The following is a description of a gene set: species: Homo sapiens Human Gene Set: GSE27786_LIN_NEG_VS_MONO_MAC_UP from publication Konuma T, Nakamura S, Miyagi S, Negishi M, Chiba T, Oguro H, Yuan J, Mochizuki-Kashio M, Ichikawa H, Miyoshi H, Vidal M, Iwama A (PMID 21540074) Genes up-regulated in comparison of lineage negative versus monocyte macrophages. Each fraction of mouse hematopoietic cells was purified by cell sorting from bone marrow of 8-week-old C57BL/6 mice, and its gene expression was analyzed., and this is the list of marker genes: CFAP418, DHFR, UBR7, RPP14, IFT27, GINS1, DTYMK, THNSL1, TDP1 (tyrosyl-DNA phosphodiesterase 1), NOC3L, PSMD2, SACS, ECD, PUS3, CHD9, METTL15, MFHAS1, STRAP, SEPTIN8, AP1B1, ARID1B, RDX, IPO11, HRAS, WIPI2, ARK2C, BCLAF1, SNHG6, ARFGAP3, MED13, USP15, UTP20, TRRAP, ECI2, MCM3, SH2D4A, TELO2, TBRG4, CSGALNACT1, TRIM27, DNAJA4, CXCL13, ABITRAM, NEK2, TMEM178A, NCBP2, AMACR, LIAS, TEX10, ZNF799, PTRH2, ESAM, ART4, TMEM39B, EARS2, TFPI (NCBI Gene Id 7035), TCF12, RASA4, DNAJC21, DYNC2I1 (NCBI Gene Id 55112), IARS2, RNMT, PIAS2, RPUSD2, ARB2A, FAM241B (family with sequence similarity 241 member B), CYB5R3 (NCBI Gene Id 1727), INSIG1, EI24, DCUN1D1 (NCBI Gene Id 54165), ZFP57, COPRS, LZTS2, SRSF7, RRP1, HNRNPU, UBE3A, STRBP, PRPF19, MTREX, SLC7A14, MNS1, SRFBP1, CD96, SLC29A1, GTF3C6, GCN1, KLHDC2, NDUFS3, NOP16, POLR3G, RSL24D1, TOGARAM1, TMEM191C, GOLM1, DRG2, ENG, ADI1, HMG20A, ETNK1, SMARCD1, LAP3, MCM7, MRPL2, PSMA4, IK, WDR77, SREBF1, LRRC66, TRMT2A, XRCC5, ZC3H15, LCMT2, MED23, ARL4A, GLT8D2, NIPSNAP1, GNPDA2 (NCBI Gene Id 132789), TRMT10B, CEP290 (centrosomal protein 290), STEAP3, HAUS3, POU2AF1, ORC4, NDUFA12, DDX19A, BTG3, RPL24, ITFG2, FOXA3, SKIC8, PRKCA, NLK, FARSA, MCAT, MYO5C, AKR7A2, LRBA, FXR1, MAPK1, PI4K2B, DDX46, PSMB2, TMEM70, TTC27, ST7 (NCBI Gene Id 93655), BLK, EIF2D, SUPV3L1, SMCO4, CMTM7, KDM1A, GTF3C4, RMND1, YRDC, MTAP, DYNLL2, NONO, IFT74, GSTT2, PFKL, AGTR1, REXO4, GATA3, POLE, PRR3, KCNQ1OT1, MPHOSPH6, NAA10, PSMA3, OTULIN, PTOV1, C19orf47 (NCBI Gene Id 126526), COPS3, UQCR10, ISX, ZBTB45, NFYC, BORA, MRPL37, ALKBH7, LGI1, NPEPL1, LTV1, ZMAT2 (NCBI Gene Id 153527), MAT2A, DRG1, HMGN3, CHURC1, CTU1, RPL22L1, PAQR8, DAP3, NSDHL, REPIN1, CIPC, RGS12, PDK1, ZNF579, UBA1